Given this list of marker genes NEDD9, INS, ZNF804A, ABHD17B, HOMER1, MIR30B, FCGR2B (NCBI Gene Id 2213), APOE, ZMYND8 (zinc finger MYND-type containing 8), FYN, CFL1 (cofilin 1), APP, GRIN2B, VPS35, PRNP, here is a description of the gene set: Any process that modulates the frequency, rate or extent of dendritic spine maintenance. species: Homo sapiens Human Gene Set: GOBP_REGULATION_OF_DENDRITIC_SPINE_MAINTENANCE